The following is a description of a gene set: Genes predicted to be targets of miRBase v22 microRNA mmu_miR_7219_5p in miRDB v6.0 with MirTarget v4 prediction scores > 80 (high confidence targets). species: Mus musculus Mouse Gene Set: MIR_7219_5P from publication Chen Y, Wang X (PMID 31504780), and this is the list of marker genes: Yaf2, Col4a1, Hsd17b7, Erbb4, Cdk17, Sde2, Mcu, Rufy2, Hoxd13, Pus7l, Vsig10l, Col5a2, Plxdc2, Cckar (cholecystokinin A receptor), Plxnc1, Rasef, Crispld2, Septin7, Ephx3, Xirp2, Kbtbd8, Aqp4, Hook3, Nxpe2, Mtf1, Rsph4a, Ccdc43, Atp2c1, Krba1, Stau2, Adam9, Cpt1a, Ank2, Dlg2, Itch, Arpp21, Igf2bp3, Heatr5a, Tmtc2 (transmembrane and tetratricopeptide repeat containing 2), Zfp46, Selplg, Tnfrsf10b, Rhpn2, Zfp326, Galc, Synpo2, Camk4, Vegfa, Tsc22d2, Rragc, Nudt4, Emx2, Nr4a1, Zfp366, Mocs2, Tgfbr1, Galnt7, Sptbn1, Gpd1, Fam107a, Ndp